The following is a description of a gene set: from publication Chen Y, Wang X (PMID 31504780) studied in species Mus musculus Mouse Gene Set: MIR_1251_3P Genes predicted to be targets of miRBase v22 microRNA mmu_miR_1251_3p in miRDB v6.0 with MirTarget v4 prediction scores > 80 (high confidence targets)., and this is the list of marker genes: Camk1d, Palmd, Zmpste24, Cep120, Rcor3, Rprd2, Cntn4, Prkra, Xkr6, Slc34a2, Myadm, Tdrp, Ptpn2, Sash1, Cpeb2, Rgs18, Nectin1, B3galt1, Tmcc3, Tex2, Prkn (NCBI Gene Id 50873), Nrk, Rnf19a, Gucy1a2, Kansl1, Dio2, Gad1 (glutamate decarboxylase 1), Nr1d2, Ngf, Reep4, Eif2s3x, Kctd9, Igf2bp2, Fhip1a, Upf2, Mbnl3, Ube4b, Larp4b, Nap1l3, Camta1, Vopp1, Hectd2 (NCBI Gene Id 226098), Prdm1, Tiparp, Ankrd44, Nrl, Tnc, Nufip2, Bcl11a, Map3k7cl, Pcsk7, Runx1t1, Bet1l, Tusc1, Tmpo, Cep350, Zfp273, Aebp2, Mafg, Kif1b, Senp7, Macf1, Grm5, Sp4, Cd47, Psg29, Slc7a14, Arhgap5, Krtap9-22, Sorcs1, Katnal1, Vezf1, Cnot6l, Msra, Flrt2, Camk1g, Lmo3, Slc19a2, Spata13, Ark2n, 9330159F19Rik, Ythdf3, Wdr72, Kctd2, Shprh, Gclc, Col5a2, Chrm3, Frmd4b, Mecp2, Mmp24, Dpp4 (dipeptidylpeptidase 4), Jchain, Mitd1, Cilk1, Slc24a2, Dyrk1a (NCBI Gene Id 76465), Enpep, Rbm39, Efr3b, Usp31 (ubiquitin specific peptidase 31), Ppp2r1b, Retreg3